Given this list of marker genes Zmpste24 (NCBI Gene Id 230709), Snta1, Nos1ap, Akap9, Kcne5, Cacna2d1, Gja1 (gap junction protein, alpha 1), Gja5, Rnf207, Kcne2, Ank2, Wdr1, Kcne4, Kcnh2, Cav3, Kcnh6, Kcnq1, Kcne1, Scn1b, Scn5a (NCBI Gene Id 20271), Kcne3, Scn4b, here is a description of the gene set: studied in species Mus musculus Mouse Gene Set: GOBP_REGULATION_OF_VENTRICULAR_CARDIAC_MUSCLE_CELL_MEMBRANE_REPOLARIZATION Any process that modulates the establishment or extent of a membrane potential in the polarizing direction towards the resting potential in a ventricular cardiomyocyte.